The following is a description of a gene set: species: Mus musculus Binding to a vascular endothelial growth factor receptor. Mouse Gene Set: GOMF_VASCULAR_ENDOTHELIAL_GROWTH_FACTOR_RECEPTOR_BINDING, and this is the list of marker genes: Vegfc, Angpt4, Pdcl3, Grem1, Ccdc88a, Vegfd, Itgb3, Dab2ip, Vegfb, Angpt1, Cadm4, Angpt2, Vegfa, Pgf, Cdh5, Cd2ap